Given this list of marker genes LUZP1, GABRD, TTR, SPEN, IDUA, GDF6, GPR101 (G protein-coupled receptor 101), PDE4D (phosphodiesterase 4D), PRKAR1A, MYH3, TBCE, ADAMTS10, UBE4B, AIP, AKT1, IDS, PRDM16, ARSL, NOG, RERE, MEOX1, SKI, KIAA0586, PRKCZ, FGFR3, KANSL1, PDPN, EXTL3, CASZ1, RIPPLY2, MMP23B, IARS2, ENPP1, RRAS2, KCNAB2, ZFX, BMP4, GDF3, ZNF341, FBN1, TRPM3, PHEX, CSPP1, NFATC2, HSPG2, PHF6, DMP1, here is a description of the gene set: Human Gene Set: HP_SPINAL_CANAL_STENOSIS studied in species Homo sapiens Spinal canal stenosis An abnormal narrowing of the spinal canal.